Given this list of marker genes LARGE1, PLP1, SBDS, SPTBN4, CDKN2A, PRR12, PRG4, ASXL2, CBS, RAI1, CREBBP, CUL7, MYBPC1, SLC12A5, BUD23, GRIA3, INPPL1, DHCR7, FKRP, COG7, PIBF1, MKRN3, IFITM5, MT-TL1, EMC1, IARS2, MESP2, SLX4, EIF5A, EGR2, CBY1, GBA2, YWHAE, FRAS1, EZH2, ALG11, RAB5IF, CTCF, ALDH3A2, SUFU, RPL35A, MYO9A, RPS17, TMEM237, BRD4, HTRA1, PPIB, CLCN7 (NCBI Gene Id 7814), PGM3, RFT1, SCYL2, TOMM7, TINF2, POMT1, WNT4, KIF15, KAT6B, SIX3, PRORP, FARS2, NIN, MEIS2, NRCAM, B3GLCT, FGF10, CDK10, HYCC1, FLNA, TCF12, MOGS (mannosyl-oligosaccharide glucosidase), FLRT1, NAGLU (NCBI Gene Id 4669), MAPK8IP3, COL12A1, BBS5, HNRNPH2, SMARCD1, GTPBP2, LTBP4, RPGRIP1L, NBAS, DKK1, NCAPG2, PHGDH, ATP6AP2, MATN3, CLIP2, WNK1, TAF1, FGD4, NAA10, SMOC1, OTUD7A, ANKRD55, ASXL1, SLC2A9, SETD5, ACTB, H1-4, NAA20, VAMP1, TMEM218, MYMK, PISD, DUX4L1, ACTG1, TAF6, ATP6V1A, MTTP, TBCD, CAPRIN1, MIA3, KRIT1, PET100, MBD5, SMS, RBBP8, PRKCZ, SIX6, LFNG, CDH11, HES7, FKBP6, TUBGCP4, DKC1, BCOR, PRPS1, SGCA, CEP152, PPP1R12A (NCBI Gene Id 4659), CLCN3, CCDC28B, H19, DHCR24, GDF5, CHN1 (NCBI Gene Id 27011), PUF60, SEMA5A, MRPS28, PHF6, HELLPAR, RPS26, CFH, PIK3CD, BICRA, PRDM5, RPS27, KCNN3, KIAA0753, MORC2, MSH4, IDUA, HS2ST1, MSL3, IL1RN, CC2D2A, RIT1, SLITRK2, GMPPB, RPL9, GUSB, MFN2, GNS, RPL8 (ribosomal protein L8), LSM11, TRAPPC9, CDK13, LZTR1, SLC35B2, DYRK1A (NCBI Gene Id 1859), SPG11, KCNAB2, HMGB3, FBXO28, DICER1, LUZP1, ARID1A, TRAPPC11, USP7, CHD3, VAC14, NUP188, TBC1D24, USF3, FREM2, ANO5, OBSL1, DYNC2I2, HESX1, TGFB2, SYT1, RNF113A, AHDC1, BCR, NFIX, ABCC6, ADA2, PTDSS1, ATP6V1B2, DES, GPC6, TWIST2, TENT5A, TTC8 (NCBI Gene Id 123016), ALPL, MTRR, ALDOA, HNRNPK, GPC4, DYNC2H1, RDH11, MT-ATP8, SNUPN, PIK3CA, PLCH1, ATP7B, IDS, ERLIN1, AK9, WDPCP, HIC1, LETM1, TLK2, PPP2R5D, SLC1A2, AGA, FXN, RNF125, TREX1, GABBR1, HACD1, ALG1 (ALG1 chitobiosyldiphosphodolichol beta-mannosyltransferase), POLG, AHI1, CNOT2, DNAJC21, KCNQ1OT1, BUB1B, PPP1R15B, DNAL4, LAGE3, RBCK1, IFT43, CTDP1, RINT1, SHMT2, YWHAG, PKDCC, HPGD, EXT2, GDF6, POMGNT1 (protein O-linked mannose N-acetylglucosaminyltransferase 1 (beta 1,2-)), RYR3, TMEM38B, DHPS, ZMIZ1, GAD1, SHH, PRX, WDR11, FGFR2, LONP1, NMNAT1, PCYT1A, MID1, YIF1B, COLEC10, MGME1, GDAP1, KMT2A, HYAL1, OCRL, TGFBR1, HNRNPR, OTX2, ZDHHC9, FHL1, NDUFAF5, EHMT1, BRF1, KCNJ6, TFAP2A, CHAT, FANCM, SCARF2, MED12, HOXD13 (homeobox D13), PTCH1, MAFB, PRKAR1A, H3-3B, RFX7, TXNDC15, ADNP, NKAP, SLC35A2 (NCBI Gene Id 7355), MKS1, XYLT2, NDUFA12, PLEKHG5, NDRG1, TRIO, GABRA3, TRAF7, TUBB4A (tubulin beta 4A class IVa), BBS7, SCAPER, DYNC2I1, RPS19, NACC1, ZIC2, KANSL1, LYSET, SDHD, MICU1, APC, ANKH (ANKH inorganic pyrophosphate transport regulator), POMK (NCBI Gene Id 84197), ATG7, SLC25A22, BRCA2, TBCK, RIPPLY2, STAG2, TRPS1, LMNA, SUPT16H, USP48, TRAIP, HIBCH, IFT27, RBM8A, SPRED1 (sprouty related EVH1 domain containing 1), TANC2 (NCBI Gene Id 80259), DCX, STX16, PIGW, EXTL3, HRAS, POLR1C, PIGA, SRP54, PMP22, SLC6A1, SPRTN, CEP104, RNU4ATAC, MRPS34, SUZ12, LHX3, LSS, HGD, ERCC5 (NCBI Gene Id 2073), TRRAP, DISP1, COL2A1, SYNE2, L1CAM, HMGA2, ZMYM3, MCM3AP, RRAS2, AGRN, CARS1, GOSR2, POU1F1, PCGF2, SCAF4, PDCD10, CFAP410, TMEM67, NDUFAF6, SLC2A1, RAB23, ELP1, NOTCH2NLC, GAS1, ADAMTS10, PIGU, FANCF, MAN1B1, TBX1, SLC37A4, PIGG, PUM1, LAMA5, TBCE, GLI3, FOXC2, PABPN1, BRCA1, ANKRD17, CHST11, AP5Z1, FSHR, WNT3, POMT2, AIMP1, PDPN, B3GAT3, WDR35, HNF1B, TERC, MPV17, DUX4, CDC42, RPL10, KYNU, FOXH1, PALLD, QRICH1, ADA, SAMHD1, TBX4, RBM28, CD46, RERE, TRIM32, HNRNPH1, IL2RA (NCBI Gene Id 3559), NAB2, ZC4H2, CYP27A1, PWRN1, PGAP1, STAT3, ORAI1, MARS2, SPTBN1, COL1A2, LARP7, WLS, SERPINH1, SH3TC2, HOXA13, SH3PXD2B, NT5E, GNAS, PPM1D, MED13L, CPOX, GJA1, EBF3, AFF3, NODAL, DACT1, SPOP, MEGF8, CCDC47, SCLT1, ALG9, NPHP1, CTNND2, UBE2T, GPC3, BNC1, MESD, GLS, FKTN (NCBI Gene Id 2218), PDE6D, CASZ1, PROP1, DYSF, HNRNPA2B1, SHOC2, AKT1, TTPA, WBP11, GAN, RIN2, RAF1, ATL1, FN1, SCN9A, ARSL (NCBI Gene Id 415), TFE3, BMP4, PAX2, ADGRG6, LHX4, SLC2A10, RPS6KA3, C2CD3, KIF7, GRIN1, SPG7, AP1S2, DNM2, WNT5A, ABHD16A, DDX3X, CUL4B, CNP, ATP6V0A2 (NCBI Gene Id 7854), TTC19, MYO1H, CAMK2G, TMEM53, PSAT1, ADAMTSL2, LMOD3, EXOSC5, PQBP1, UBE4B, KDELR2, CDC45, USP8, WIPI2, ATP6V1E1, FLAD1, COG1, GALNS, CLIC2, COX7B, BBIP1, BPTF (NCBI Gene Id 348241), NPR2, POC1A, NHP2 (NCBI Gene Id 55651), CDK19, NEPRO, UFSP2, OTUD6B (OTU deubiquitinase 6B), ALDH18A1, COL5A1, RNF13, NUS1, MBTPS2, TMEM43, GLI2, CRPPA, WDR73, OCA2, GPR101, PIGL, PCNT, KLC2, DMPK (NCBI Gene Id 60405), AMN, CRLF1 (NCBI Gene Id 9244), KIAA0586, HINT1 (histidine triad nucleotide binding protein 1), PRKG2, GABBR2, TMEM165, BDNF, HGSNAT, TMEM147 (transmembrane protein 147), PALB2, ZIC3, MYH11, SMARCC2, ALG13, METTL27, DHX37, CCND1, TMTC3, POLR3GL (NCBI Gene Id 84265), NEK9, SLC9A6, CRTAP, ROR2, DSE, PSMC3IP, TRAPPC4, POR, FANCI, CFI, LEMD3, WAC, TTI2, MAP3K20, FLCN, FLNC, GNPTG, TBL1XR1, LTBP1, RPL18, NTN1 (netrin 1), NPAP1, PHKG1, MAX, SUMF1, PYROXD1, NOTCH2, PDE4D, ANTXR2, FOXA2, TIMM50, PTPN11, UBE2A, FUCA1, PIEZO1, PIEZO2, SCUBE3, JARID2, CEP55, HMBS, ARPC5, TPI1, FAM20C, SKI, ITGA7, PRMT7, UBE3A, FOXF1, EIF4H, PIGT, SMARCAL1, NXN, ACBD6, SPARC, SSR4, KCNT1, BBS1, RNASEH2B, PDZD8, STAG1, EFEMP1, CDC42BPB, ARL13B, ARFGEF2, MRPL12, AIFM1, HACE1, MPZ, SMARCA2, CHD4, PDE11A, PMM2, SYNJ1, SMCHD1, SHROOM4, PTH1R, POLE (DNA polymerase epsilon, catalytic subunit), SLC39A14, FANCL, MMP14, SPEN, DPM2, TARS1 (threonyl-tRNA synthetase 1), INTS1, ECEL1, HSPB8, SLC25A42, TGFB3, ERCC4, TWIST1, SF3B4 (splicing factor 3b subunit 4), NBN, NF1, WDR4, GRIP1, AMER1, PLAAT3, ARPC4, MANF, BCL11A, NRXN1, FKBP10, MFAP5, MYLK, KCNQ2, HEATR3, FKBP14, RPS10, IGHMBP2, USP9X, RSPRY1, STAT6, TTC5, PLCB3 (phospholipase C beta 3), SDHB, RAC3, ITPR1, RPL27, NR5A1, AMMECR1, GJA5, COMT, MAD2L2, GLB1 (galactosidase beta 1), TCTN2, NR3C1, TTC21B, CEP290, ATRX, BGN, SMARCE1, DMP1, PHF8, NECTIN1, PODXL (NCBI Gene Id 5420), MYMX, P4HTM, COX8A, BMP1, HUWE1, OFD1, FBN2, IDH1, INPP5E, MAPK1, GTF2E2, RAD21, DNAJC30, ALG8, CHMP1A, DNMT3B, SURF1, AHSG, SCN2A, VMA21, TMEM216, PGAP3, DVL3, DDRGK1, GJA8, MAPT, SLC52A3, ARSB, MYPN, PIGS, TGFB1, LAMA2, C1R, CCDC22, IRF6, GARS1, IMPDH2, NADSYN1, ZIC1, JPH1, SYT2, SACS, SATB1, TMEM270, LIPE (lipase E, hormone sensitive type), RPS7, FZD2, RAB18, THSD4, PACS1, CTSK, LRRK1, BMPER, RUSC2, PRDM13, ZNF469, SMAD3, RSPO2 (R-spondin 2), USB1, GJB1, SPTSSA, WWOX, NUP133, PRKG1 (protein kinase cGMP-dependent 1), VDR, POLR1A, FOXP2, MMP23B, RB1, ARL6, POLR1D, TALDO1, SLC35A3, RBM10, RTL1, SMC5, MRAS, KCNA1, SMARCA4, MADD, MEGF10, ZFX, FLVCR1, SMARCB1, SEC24C, TCTN3, MEOX1, VANGL1, PAX7, SRRM2, NEFL, ITGA8, PARN, RASA1, DNA2, BRIP1, SETBP1, SLC18A3, TP53RK, DPF2, PPOX, EP300, NEB, COL9A2, GZF1, SOX3, OTUD5, ATN1, TCTN1, SPTAN1, ZEB2, KLLN, PIGO, ARL3, COL9A1, DLK1, MAN2B1, GTF2IRD1, ADCY5, ALG14 (ALG14 UDP-N-acetylglucosaminyltransferase subunit), COG8, SALL4, MAP2K1, HHAT, FARSB, GBA1, GLIS3, HDAC4, MNX1, MTRFR, PLXNA1, ACTA1, NDN, CDH23, CAMSAP1, IQSEC2, APTX, CRIPTO, FAT4, SNORD116-1, DLG4, WNT7A, KY, BAP1, NEK1, MGAT2, MYL11, NSDHL, DNMT3A, POLA1, COMP, FARSA, SBF1 (NCBI Gene Id 6305), SIL1, TAF4, NSD2, VPS37A, SLCO2A1, ARVCF, NGF, SETX, ANK1, GNA11, RAB3GAP2, WASHC5, PYCR1, TNPO3, LRP5, LAMB2, CHD7, PLCB1 (NCBI Gene Id 23236), ARSK, ARF1, FGF8, GP1BB, RET, TBX6, SPTLC1, KCNJ8, SON, MAPRE2, CCDC32, TNFRSF1A, SLC29A3, XYLT1, ZNF699, UBE3B, PPP2R1A, SFRP4, TP53, DPAGT1, GPX4, MBTPS1, CCDC134, EXOC6B, TRPM3, IGBP1, FOXRED1, BICD2, TERT (telomerase reverse transcriptase), RNASEH2C (NCBI Gene Id 84153, ribonuclease H2 subunit C), SOCS1, NDP, FBXL4, TTN, SELENON, VCP, TELO2, THPO, ELN, NFU1, SEMA3E, SNX14, MYH3, TBX15, MMP2, SLC35D1, NPM1, ERCC2, RPL35, KMT2E (lysine methyltransferase 2E (inactive)), KIF21A, PIGV, SLC52A2, IHH, RPL13, JAG1, CTBP1, CAPN3, MAP1B, NARS1, SPAST, TGIF1, MMP13, ATAD1, WRAP53, CLCF1, SDHC, PHKA1, CLDN11, RRM2B, LMNB2, DCC, ERMARD (ER membrane associated RNA degradation), C1S, RUNX2, SNAP25, GFPT1, GTF2H5, NCF1, PRDM16, UBA1, COQ6, TYMS, PLOD1, RNASEH2A, SMPD4, KLHL7, COL25A1, ALG2, IL2RB, TNFRSF11A, PSMD12, PAX6, CCBE1, BMP15, HIRA, PHLDB1, VPS13B, CRELD1, RAPSN, GNPTAB, CREB3L1, TTI1 (TELO2 interacting protein 1), SHANK3, BANF1, NUP88, FRG1, CD247, SP7, CLP1, MEFV, ATAD3A, VPS37D, PIGQ, NDUFB11, RASA2, COL1A1, WNT1, RRAS, NALCN, B3GALT6, LIMK1, NLRP1, ATRIP, TMCO1, DLL3, CHRNG, PLOD2, TOR1AIP1, SNRPB, IFT80, PGAP2, SPRED2, RECQL4, NOP10, EED, HAAO, SPIDR, BBS4 (NCBI Gene Id 585), GON7, CHD8, NUP85, COLQ, SEC23B, DCHS1, UBTF, CFAP418, KDM6A, RPL31, PDGFB, CDK5, BBS2, PLOD3, AIP, NGLY1, CTC1, WDR81, GORAB, TUBA1A, SMC3, ASXL3, MINPP1, CACNA1S, SCN4A, DDX6, EIF2AK3, MAT2A, TUBB, RFWD3, MRPS22, BBS10, IDH2, ZNF423, SPART, COL27A1, RNU4-2, UFC1, POGZ, PI4KA, MKKS, CSPP1 (centrosome and spindle pole associated protein 1), COQ4, TGFBR2, FANCD2, ALG12, GGPS1, SYNE1, ROBO3, SEC63, GH1, ENPP1, FANCE, KIF5A, CHRNB1, PORCN, SLC25A1, BPNT2, TPM2 (NCBI Gene Id 7169), SOX5, CIC, MTMR2, ERLIN2, PTEN, IFIH1, TK2, ACADS, GNPAT, VANGL2, B9D2 (NCBI Gene Id 80776), PLK4, ASH1L, UFD1, RTTN, TONSL, TCOF1, ARL6IP6, FLNB, SCN1A, NOG, NEU1, COL10A1, LZTFL1, EFL1, APC2, SIGMAR1, LMX1B, JAG2, YARS2, ADAR (NCBI Gene Id 3427), SIN3A, MARS1, TRAPPC2, NIPBL, CCN2, MLXIPL, ATP2B1, NDUFS3, WRN, DAG1, HSPG2, SOX9, SRY, WT1 (WT1 transcription factor), NDUFAF1, DLL1, DMD, PTPN2, NEDD4L, PEX7, PAX3, CFL2, CASK, TUBGCP6, DVL1, PIGY, AEBP1, MUSK, ERF, CACNA1G, PAICS, CHRNE, CSNK2A1, DPP6, HERC1, RPL11, GPKOW, IFT140, GJC2, GNB2, UROS, ATR (NCBI Gene Id 57307), KMT2C, H4C9, BRPF1, SLC5A7, VPS33A (NCBI Gene Id 65082), PRUNE1, CAPN1, TPM3, TRIP4, NDUFAF4, CHRNA1, TGDS, ODC1, HECTD4, DYM, CBL, NSUN2, TPRKB, B9D1, PPP1R21, GDF11, SLC25A24, CCDC8, KCNH1, CTNNB1, COG5, PLEKHM1 (pleckstrin homology and RUN domain containing M1), SLC26A2, PDGFRB, GFM2 (NCBI Gene Id 84340), SMO, SLF2, POU4F1, ALS2, GFAP, FLI1, SGSH, MPLKIP, CADM3, ACTN2, SOST, ABL1, FOXG1, TCIRG1, RAB3GAP1, WNT9B, HK1, SDCCAG8, ANKRD11, PYCR2, SRD5A3, TP63, B4GALNT1, ZMYM2, HCCS, DPYD, TRPV4, RNU12, LRP4, NRAS, DNAJC6, SF3B2, BBS12, PAPSS2, FBN1, COL13A1 (NCBI Gene Id 96775), AARS1, CHST14, RPL5, LGI3, PIGN, FTO, TOR1A, CHRND (cholinergic receptor nicotinic delta subunit), KBTBD13, ARID1B, NKX6-2, ZSWIM7, TNNT1 (troponin T1, slow skeletal type), IL6ST (interleukin 6 cytokine family signal transducer), COLEC11, NONO, NTNG1, HSD17B4, COQ2, RAD51, FLII, TMEM63C, VPS53 (VPS53 subunit of GARP complex), COL5A2, COL6A3, CAMTA1, SLC30A9, KMT2D, LIG4, IPO8, SLC22A12, KRAS, GFRA1, SC5D, UBAP2L, FILIP1, SMAD4, KLHL41, GET4 (NCBI Gene Id 51608), DHX30, ADAMTS2, TRMT10A, SVIL, INPP5K, PIK3R2, SNRPN (small nuclear ribonucleoprotein polypeptide N), VHL, TECPR2, PPP1CB, TAPT1, SNORD115-1, DEAF1, FUZ, CPLANE1, MASP1, CENPT, AIMP2, GTF2IRD2, ITGB6, SCARB2, UPF3B, EXOSC9, AUTS2, B4GALT7, COL9A3, STAC3, PRKCSH, FBLN5, MTMR14, SOX11, MAPKBP1, HNRNPA1, SOS2, MYH2, TBC1D20, ASAH1, SOX2, PHACTR1 (NCBI Gene Id 81705), LOX, LIFR, HPDL (4-hydroxyphenylpyruvate dioxygenase like), GABRD, SH2B1, RAB33B (NCBI Gene Id 83452), FANCA, CCN6, CLCN4, POLD1, UPB1, TUBB3, MED12L, CENPE, NKX3-2, TMEM231, CCL2, NR4A2, RTEL1, ADAT3 (NCBI Gene Id 113179), INTU, MSTO1, DHODH, TRAPPC12, PWAR1, CEP41, ITCH, COL11A1, FANCG, SMG9, MYL2, RAD51C, DONSON, KNSTRN (kinetochore localized astrin (SPAG5) binding protein), SLC10A7, TRIP11, KCNK9, COG4, CEP19, PLAA, CAPN15, RYR1, CD96 (NCBI Gene Id 337949), SIM1, GRB10, RNU7-1, GATA4, BMP2, CTSA, ATP7A, TBX18, PAM16, FGFRL1, COL3A1 (collagen type III alpha 1 chain), BAG3, POLR3H, HDAC8, FMR1, FUS, SRCAP, ZNF407, HNRNPU, COL11A2, TSR2, SBF2 (SET binding factor 2), HTT, ESCO2, AP1G1, ALDH1A2, MPL, ACVR1, AFG2A, TNNI2 (NCBI Gene Id 7136), TTR, HSPD1, GREB1L, TOGARAM1, CHKA (NCBI Gene Id 1119), SATB2, GSC, COL6A2, OSGEP, PTPN22, PPP2R3C, KIF26A, RIPK4, PLCB4, SGCG (NCBI Gene Id 6445), SEC23A, GDF3, RTN2, ADAMTS15, ALG6, GNE, GNAQ, DOK7, MYF5, TMEM138, RFC2, P3H1, EMD, ANXA11, KATNIP (NCBI Gene Id 23247), NSD1, NUP107, NANS, ERCC8, GATA1, ACP5, H4C5, IFT172, TCF4 (transcription factor 4), NOTCH3, HLA-B, CHRM3, PEX5, TCF20, RREB1, STIL, BIN1, NELFA, NTRK1, ORC1, HDAC6, PNKP, BMPR1B, DSTYK, MAGEL2, TBX5, MYOD1, IKBKG, RPS28, SORD, POLR1B, CRKL, BAZ1B, PNPT1, GNPNAT1, CDON, IGF2, SGMS2, FGF20, VRK1, PUS1, SALL1, POP1, CAVIN1, DPP9, DDX59, ZMPSTE24, AFG2B, CYP7B1, RETREG1, STAT4, SEC24D, STXBP1 (syntaxin binding protein 1), FGD1, ALMS1, EXT1, MEG3, TNFRSF11B, KIF22, LMNB1, ZNF341, KCNJ2, SUGCT, CANT1, HEY2, STX1A, ABCC9, DDR2, SLC25A46, MAP3K7, ERCC6, ERGIC1, RPS29, FA2H, TBXT (NCBI Gene Id 6862), MYO18B, MAF, XRCC2, EFNB1, SPEG, FGFR3, KIFBP, JMJD1C, CSGALNACT1, CHST3, KCNJ5, SHOX, GTF2I, PTCH2, GCH1, HERC2, TBXAS1, BBS9, DPYSL5, RPS15A, IFT74, POLR3A, GLE1 (GLE1 RNA export mediator), BRAF, AFF4, PLEC, FOXE3, SOX4, RPL15, PIK3C2A, MED25 (NCBI Gene Id 81857), ACTA2, ANTXR1, CPLX1, RPL26, TNNT3, UNC80, KIF1A, PAFAH1B1, COL6A1, ACAN, WNT3A, SMAD2, GALC (NCBI Gene Id 2581), P4HB, MAN2C1, ABCD1, CCM2, HSPA9, ALX3, ARID2, RPS20, DEGS1, KDM1A, RABL3, COPB1, SOS1, AXIN1, DLX5, ARX, RIGI, MAP2K2, PHEX, RPS24, SLC12A6, ASCC3, OXR1 (oxidation resistance 1), ZBTB20, ARMC9, FAM111B, SLC16A2, HBA1, LBR, SMC1A (structural maintenance of chromosomes 1A), NFATC2, DNAJB4 (NCBI Gene Id 11080), SAMD9, FANCC (FA complementation group C), HBA2, LTBP3, RNASEH1, SLC25A21, TBX2, HYLS1, MECP2, DDHD1, SLC39A13, RMRP, EBP, MVK, CEP120, SERPINF1, NF2, CSF1R, ERI1, MYH7, ERCC1, VPS35L, ERCC3, MAB21L1 (NCBI Gene Id 4081), RAC1 (NCBI Gene Id 5879), FANCB, TMEM94, WDR45B, TBL2, FGFR1, FIG4, NEMF, TBR1, DNM1L, CDKL5, PRKD1, FUT8, YRDC, here is a description of the gene set: studied in species Homo sapiens Any abnormality of the vertebral column. Human Gene Set: HP_ABNORMALITY_OF_THE_VERTEBRAL_COLUMN Abnormality of the vertebral column